The following is a description of a gene set: Thrombocytosis species: Homo sapiens Increased numbers of platelets in the peripheral blood. Human Gene Set: HP_THROMBOCYTOSIS, and this is the list of marker genes: RPS17, JAK2 (Janus kinase 2), PIK3CD, SKIC3, THPO, ADA2, RPS10, REL, RPL9, LACC1, RPS19, RUNX1, GATA1, RPS20, TP53, TGFB1, ATP6V1B2, RPS27, RPL18, RPL31 (ribosomal protein L31), RPSA, HMOX1, CALR, ELANE (elastase, neutrophil expressed), TBK1, RPS14, PSTPIP1, TTC7A, ACAT1, RPS7, MPL, SF3B1, SKIC2, ABL1, RPS24, RPS29, HEATR3, RPL35A, TSR2, RPS28, PMM2, HLA-DQB1, RPS26, RPL26, RPL5, RPL8, TBC1D24, KCNN4, RPS15A, IFNGR1, RPL27, HLA-DQA1, RPL15, MARS1, MTHFD1, TET2, SH2B3, STING1, IFNG, CD55 (CD55 molecule (Cromer blood group)), BCR, HMGCL, RPL11, ELF4, ASL, HBB, RPL35